Given this list of marker genes POLR3A, CPLANE1, COL11A1, RAB34, CCN2, TBX4, PUF60, SUCLG1, UBAP2L, TBX15, TAPT1, MTHFS, CAMK2A, SERPINH1, GNPNAT1 (NCBI Gene Id 64841), COL2A1, AMMECR1, FLNB, SLC31A1, SLC26A2, TNFRSF11A, TRPV6, RNU4ATAC (NCBI Gene Id 57788), ALG12, TGDS, GDF5, FGFR3, BHLHA9, IHH, SALL4 (spalt like transcription factor 4), AGPS, here is a description of the gene set: species: Homo sapiens Human Gene Set: HP_SHORT_FEMUR An abnormal shortening of the femur. Short femur